The following is a description of a gene set: Human Gene Set: GOBP_POSITIVE_REGULATION_OF_STEROID_HORMONE_BIOSYNTHETIC_PROCESS Any process that increases the frequency, rate or extent of the chemical reactions and pathways resulting in the formation of steroid hormones,compounds with a 1, 2, cyclopentanoperhydrophenanthrene nucleus that act as hormones. species: Homo sapiens, and this is the list of marker genes: POR, DAB2, NR5A2, WNT4, BMP6